Given this list of marker genes ARL3, NPHP3, RP2, UNC119B, CYS1, here is a description of the gene set: Human Gene Set: REACTOME_TRAFFICKING_OF_MYRISTOYLATED_PROTEINS_TO_THE_CILIUM Trafficking of myristoylated proteins to the cilium studied in species Homo sapiens